Given this list of marker genes TMEM199, CLN5, SLC11A1, TMEM9, LAMP1, CCDC115, ATP6V0E2, DMXL1, ATP6V0D2, SNAPIN, ATP6V0A4, RNASEK, PPT1, CLN6, ATP6V0A1, ATP6V1F, ATP6V0A2, TMEM106B, ATP6V1D, DMXL2, CREG1, ATP6V0C, ATP6V1B1, GRN, ATP6V1B2, ATP6AP2, TCIRG1, ATP6V1H, ATP6AP1, CLN3, ATP6V1A, ATP6V0B, CLIC4, ATP6V0E1, ATP6V0D1, LAMP2, here is a description of the gene set: Any process that reduces the pH of the vacuole, measured by the concentration of the hydrogen ion. studied in species Homo sapiens Human Gene Set: GOBP_VACUOLAR_ACIDIFICATION